The following is a description of a gene set: Mouse Gene Set: GOMF_AZOLE_TRANSMEMBRANE_TRANSPORTER_ACTIVITY Enables the directed movement of azoles, heterocyclic compound found in many biologically important substances, from one side of a membrane to the other. species: Mus musculus, and this is the list of marker genes: Slc47a2, Slc28a1, Slc22a1 (NCBI Gene Id 20517), Slc19a3, Slc7a1, Slc38a3, Slc25a19, Slc47a1, Slc38a5, Slc15a4, Slc66a1, Slc22a2, Slc44a4, Slc19a2